The following is a description of a gene set: Pre-IC formation. Pathway ID: N01470. Pathway type: Reference. Pathway class: nt06509 DNA replication. Pathway Definition from KEGG: TOPBP1+RECQL4 == POLE == GINS -> ORC+CDC6+CDT1 == CDC45+MCM+GINS == POLE+TOPBP1+TICRR+MTBP+RECQL4 Human Gene Set: KEGG_MEDICUS_REFERENCE_PRE_IC_FORMATION species: Homo sapiens, and this is the list of marker genes: ORC5, RECQL4, GINS3, MCM2 (NCBI Gene Id 94687), MCM5, TICRR (TOPBP1 interacting checkpoint and replication regulator), ORC3, GINS4, ORC6, MCM7, TOPBP1, MCM3, CDC45, MCM4, MCM6, MTBP, POLE3, POLE4, CDT1, POLE, ORC1, POLE2, ORC4, GINS2, ORC2, CDC6, GINS1